Given this list of marker genes FOXRED1, TMEM263, FBXO15, SLC38A2, MINAR1, SLC31A2, ALDH3A2, CFAP206, CD55, SH2B2, PPM1L-DT, PPP1R12A-AS2, FGD3, LINC00265, RALGAPA2, CCDC12, KCNMB4, BORA, NEBL, CHST3, FBXO3-DT, L3MBTL4, THUMPD3-AS1, ADD3, MHENCR (melanoma highly expressed competing endogenous lncRNA for miR-425 and miR-489), MTUS1, CCDC74B, HNRNPA2B1, CEP170, NEK8, SAMD13, RILPL1, GEMIN8, ATXN1L, JADE2, CAV1, CNOT2, DST, MIR4669, ABT1, ENSG00000274248, SERTAD3, KRTDAP (keratinocyte differentiation associated protein), TASOR2, CFAP74, ULK3, AP3S2, ITGB3BP, SMARCAD1, CDKN2B-AS1, ACAA2, TRIM14, HTR6, GSE1, SERTAD3-AS1, STOX1, YARS1, TIMM21, RUNX1, KAT6B (NCBI Gene Id 23522), USP9X, LRRK2-DT, RIPK4, TLE3, LMNB1-DT, TRIP6, IGF2BP2, ZNF143, SDC4, SLCO4A1, MYO3A, FXR1, NTN4, KAT2B, TMEM187, AVPI1, RAB37 (RAB37, member RAS oncogene family), SYCE2, FZD1, LNX2, LAMC1, SPSB4, LHFPL6, JOSD1, BROX, C1QTNF1 (NCBI Gene Id 81852), YKT6, APP, ZNF449, VTI1A, SART3, TRIOBP, PDE4DIPP6, ZNF286B, NEBL-AS1, GGA3 (golgi associated, gamma adaptin ear containing, ARF binding protein 3), MVK, CRTAP, BCL7B, GNAQ, NSG1, NTNG2, FBXO17, DUSP1, DPYSL2, MTF1, ALDH5A1, FLJ38576, DFFB, UBALD1, CBX4, PLS1, ZBTB1, MIR4710, RPL26, RPL9, DENND5A (NCBI Gene Id 23258), RNU1-5P (NCBI Gene Id 107105261), UNC13D, GBA2, GBA1, ADGRE5, CFL1P1, RNU1-6P, SPTBN1, TCEANC, SVIL, QPCT, NCOA4, FLNA, ZNF143-AS1, HNRNPU, FOXN3, CRTC3, VPS72, MGA, LTK, ADAMTS1, FGFR4, PNRC1, C15orf62, MAN2C1, PTPA, MAP1LC3B, METAP1, ZDHHC6, HSPA12A, TSC22D4, MET, ITPK1, BHLHE40, B3GNTL1, ARHGAP10, NEAT1, ADRB1, ARHGEF6, PELP1-DT, TUBA5P, BMPER, ZC2HC1A, ATXN1-AS1, SLC18B1, DICER1-AS1, MRPL14, TUT7 (NCBI Gene Id 79670), ISCA1, TBX18, LIAS, MRPL34, ADCK2, AAAS, STX16, ZNF501, HLA-DMA, ERC1 (NCBI Gene Id 84770), HMG20B, MAK16, LGALS8, TSPAN12, TPTEP2, ZBTB38, ZNF75D, GS1-24F4.2, BBS4, NDE1, CROCC, DGAT2-DT, PRDM10, DDIT4, TARS1, MIR6853, ANKRD36C, SOX18, CEP104, ATP5MFP1, LTV1, MARCKSL1P2, TRIM24, CFAP43, CALCOCO2, SRGAP1, FRMD6, BAG6, PIK3R1, NAGLU, UCHL5, RNPS1, RHPN2, FASTKD3, OSBPL9, NFE2L2, TRMT1, ENSG00000248367, MTF2, MCRIP2, FHIP1A, PPP2CA, SLC25A42, IL5RA, ANXA11 (annexin A11), CCNI2, EEF1D, ZNF703, APC, ZNF593, PRKCH, FRG1HP, COQ10A, TBXA2R, RASGEF1B, KCTD11, TNRC18, PPARG, SGK3, SLC16A6, IFT88, USF2 (NCBI Gene Id 7392), RPS21, FUNDC2 (FUN14 domain containing 2), AP3S1, RCOR3, EPCAM-DT, RRAGD, ABCB10, RANBP9, CNTNAP2, ZBTB7C, MAGI2, GSTK1, LGALS8-AS1, KLHDC8B, UBE3C, PPM1L, GATA3-AS1, GPR6, PSPH, MICAL1, BRF1, NIPAL4-DT, TP73-AS3, HIPK3, CAPN1-AS1, RIOK1, LINC02026, F12, IDUA, NHSL3, CREB3, CC2D2B, NUS1, GCNT2, LINC01126, ABCG4, STK10, LZTS2, TOP3B, WIPI2, DGKQ, CYP2E1, HDGF, PLD1, CDK8, GPR146, VPS26C, MAP3K5, ATF3, RETREG1, ATF7-NPFF, COPB2-DT, CCDC169, NRP1, LINC01703, CHCT1 (NCBI Gene Id 124773), PLEKHA5, LINC02601, ERICH1 (NCBI Gene Id 441310), ATP1A1-AS1, EMILIN2, TRIM47, SGTB, MIR1915, TAGLN2, SLC44A1, VGLL4, AMDHD1, COL24A1, CCNL1, LIN7B, TNK2, USP2-AS1, DTX3, LSM2, ATP1A1, TLCD1, ANP32A, EMB, RALGDS, CUL4A, JAKMIP3-AS1, UBE2G2, ENTPD6, OGG1, CYP1B1, ENSG00000224865, PTK6, SATB1, TGFBR3 (NCBI Gene Id 7049), RGS9, COL25A1, RASEF (RAS and EF-hand domain containing), TCFL5, ADORA2B, CABLES2, SPRED2, GRK6, RANGRF, TMLHE, FBXO31, HSPA5-DT, DBNDD2, AIDA, UTRN, ABCA2, FAM200B, LIFR-AS1, SCRN2, SGSM2, CDCA2, B4GALT3, PTPRG (protein tyrosine phosphatase receptor type G), CYB5D2, CNOT7, DLG3, RNF207-AS1, NUDT19-DT, MIDN (NCBI Gene Id 94034), MGAT4B, SQSTM1, RNF150, KHDC1 (KH domain containing 1), CTIF, CCZ1P1, CA12, PWWP3A, CKB, CMTM8, PTPN6, PPP2R5A, TGFB2-AS1, ATAD1, FOXL1, TPRN, NPAS3, ITPR3, EDIL3-DT, EIF4H, SLC25A37, HSPA5, LTBP3, RAI1, COL25A1-DT, MTX1, MTARC1, ADD3-AS1, HCFC1, ACTN1, ZNF782, BRWD1, SLC1A1, RO60, RAD52, ZNF491, RILP, FRMD5, FBXO3, MAPK9, FGD4, FNTA, WRAP73, SYNJ1 (synaptojanin 1), GNG12-AS1, PDLIM7 (PDZ and LIM domain 7), NDUFAF3, TPT1-AS1, EIF4E1B, SLC16A1, NXNL2, CADM4, ZC3H4, PEX11A, LINC02709, SLC16A1-AS1, ENSG00000280424, ENSG00000273145, ARHGEF12, SNX3, EFNB2, C7orf50, LARP1B, CRY1, LINC00398, STK25, RPIA, CS, YTHDF2, LRMDA, AQP6, MFGE8, ZNF620 (NCBI Gene Id 253639), UQCC5, TBC1D22A, OLIG2, PAM, APC2, PRKAG2-AS1, SCN1B, MTG1, ANKRD18B, HPSE, PAXBP1-AS1, EPC1-AS2, CYP4V2, KRAS, TNFAIP3, CNPY2-AS1, MPHOSPH6, ZNF503, SH3GLB1, RPS27L, HOXB6, RCBTB2, IFNAR1, TMEM105, TMEM123, CFAP52, PNCK (NCBI Gene Id 139728), TGFB1, ROM1, MTMR14, RGS3, DIPK1A, PTGER2, PDE8A, LIMS1, HACD3, MLF2, PANK2, PCID2, EXT2, NAA16, RNVU1-3, SIM2, TM9SF1, RNU6ATAC, HOXB3, TLN1, IBA57-DT, TMEM147, GMEB2, MTUS1-DT, PRCD, APBB2, IFT25, GOPC, BLTP1, SAMD4B (sterile alpha motif domain containing 4B), PUSL1, PPP2R5C, LAMB1, LAGE3, NAIF1, CASTOR3P, EARS2, DDX59 (DEAD-box helicase 59), SPPL3, CASP6, PRKAG2 (protein kinase AMP-activated non-catalytic subunit gamma 2), SMAD2, PEX16, NHSL1-AS1, PARP3, TMEM63B, PGGT1B, WDR93, DARS1-AS1, GATA3, ELL2, SEMA6A, SLC6A8, ZNF639, RARA, MBD6, PDZD7, GPR3, SSBP2, ETS2, ZNF641, RNASEH2B (ribonuclease H2 subunit B), RNF207, TRNT1, MTRR, SPX, ORAI1, TRDMT1, MAP3K8, CUEDC1, CCNQ (NCBI Gene Id 92002), SLC20A1, LRRK2, SH2B3, SLCO5A1-AS1, BRD2, ENSG00000282904, SPATA13, CIP2A, CSAD, CHD3, ETF1, CASC9, RNVU1-15, CACTIN-AS1, ZZEF1, ADCY3, RAMP2-AS1 (RAMP2 antisense RNA 1), G0S2, PDXK, GNA13, SSR4P1, TGFB2, TMEM263-DT, DENND3-AS1 (DENND3 antisense RNA 1), BARX2, ENSG00000277020, ENSG00000266313, BDKRB2, POLR3G, LNPEP, EPHB1, GINS3, SLC20A2, LAMTOR2, F8, CDK18, CTDSP1, TXNL4A, PICALM, PLK3, DNAI3, TP53TG5, SPTBN5, PKN2, RNASET2, PIGC, MTCL1, C21orf58, ASAP2, COL13A1, TOB2, VARS1, ADSL, MARCHF7, NME3 (NCBI Gene Id 96012), KLF13, STX16-NPEPL1, SGK1, BLMH, LBX2, GCLM, IQCD, GGH, RSL24D1, SMIM13, AGAP3, CNR1, SQOR, LDB3 (NCBI Gene Id 1219), ZNF140, PPP1R16A, LINC01586, GLUL, TUBB4A, PHF12, VPS29, ATP6V0E2, VWA5B2, TUBBP5, LINC00881, DAP, KRT8, ZNF607, MISP3, UBFD1, MIR449C, FANK1, IL6ST, FAM201A, JAK2, RBP1, ENTPD1-AS1, SECISBP2, ACAP3, IQGAP2, ACIN1, TRMT9B, NEIL2, GGNBP2, FAM66B, LINC03073, RNU6ATAC34P, PPP1R3B, CHPT1, SH3D21, PNPLA3, SDCCAG8, SLC4A2, R3HCC1, CCDC88B, STMN1, EEF1A1-AS1, WDHD1, TPT1, IER2 (NCBI Gene Id 9592), MNX1, CCZ1, PGF, EPCAM, MILIP, NUDT19, SLC16A2, TTC17, PIPOX, HERC6, BATF3, RAD9B, YWHAE, LINC01424, DPH7, TCEA2, BTG2-DT, FLT3LG, FBN2, HNRNPF, TMEM91, CDC73, CYTH1, P2RX4, OCLN, CBX2, LHX1, DNAJC7, SCARNA17, ACTG1P25, ATOSA, DCLRE1A, SMARCAD1-DT, CCDC38, CCDC110, MCOLN3, CLIC4, NAALAD2, PLEKHA2, LINC03126, MYADM, YWHAQ, GAA, TRIM7, TSPAN5-DT, MIR615, N4BP2L1, STON1, TUBGCP3, NREP, CBX3, MPP2, TGIF1, DDX59-AS1, CTDSP2, ZNF740, LTBP4 (latent transforming growth factor beta binding protein 4), PELP1, CACNA2D4, DYNLL1, IRF5, ATAD3A, ZNF467, TEP1, TTC38, THAP3, SOCS4, TOM1L2, EEF1A1, MBP, ASB1, ZNF10, FBXL5, PHF3, POLR1D, ITPR2, ACVR1B, USP32, ABTB1, MED13L, CNP, XPOT (exportin for tRNA), TMEM123-DT, EWSAT1, PRDM11, LINC00620, CDC37, ITGA7, RTL8B, ANKRD18A, BLOC1S1, TWF2, TIGD3, ENSG00000236846, AKAP10, ZMYM2, STOX2, WDR86, ARID1B, MED12L, TRIB1, RNU4-2, SNIP1, ATP23, TBPL1, NT5DC2, MEF2D, RNF130, ST6GALNAC2 (ST6 N-acetylgalactosaminide alpha-2,6-sialyltransferase 2), KIF21A, ZNF517, MAP3K4, ZNF436-AS1, THEM4, FADS1, TGM2, ATG12, DPYSL4, SLCO4A1-AS2, TUNAR, DALRD3, MYO18A, UAP1, SNX10, TMEM37, SLC16A11, ARL4A (ADP ribosylation factor like GTPase 4A), PLEKHG5, INPP5B-AS1, SLC25A35, OXSR1, DPCD, GINS4, INPPL1, STX8, MYOM2 (NCBI Gene Id 9172), PDE1B, FPGS, SLC3A2, GATA6, FGF11, HSD11B1-AS1 (HSD11B1 antisense RNA 1), CEBPA, DBIL5P, CTSC, HOXB9, TSPAN9, GOLPH3-DT, EPHB6, CBX8, ZNF503-AS2 (ZNF503 antisense RNA 2), KGD4, CUX1, IST1, GPR199P, B9D1, CDK2AP2, VAMP2, RECQL5, SPART, SERPINF1, MPP3, CDC25B, SPR, GLI3, PPP3CB-AS1, STX11, SNCB, NBPF19, SAE1, BBS2, CDC20B, MTA3, HDAC1, KAZN, KDM1A, HMGN2, DLC1, CRIPT, WDR86-AS1, SCD, INAVA, GCC2-AS1, DGAT2, ZNF862, ACBD5, ARHGEF7, TMEM147-AS1, DDX55, CCNE2, GSAP, PDE7A-DT, NACC2, MATK, KMT5C, SPAG4, VARS2, MEF2C, FHIP1A-DT, BMF, DHRS3, TFRC, OSGIN1, SETD5, ITM2B, TARS1-DT, TMEM259, LRFN4, GREP1, LYPD1, SPART-AS1, CCDC33, ATXN1, METTL21A (NCBI Gene Id 151194), DENND4B, NFATC4, TTI2, PITPNM2, ITGB2, KDM4B, PPP1R18 (NCBI Gene Id 170954), CDC42EP3, GFRA3 (NCBI Gene Id 2676), HERPUD1, NIPAL4, EML2, TMEM35B (NCBI Gene Id 100506144), HOXC4, NPPB, MMAB, ZNF770, CASP8, METTL15 (NCBI Gene Id 196074), NPTX1 (NCBI Gene Id 4884), SNHG5, ANTXR2, DNAJC9-AS1, LINC01749, CCT6B, BMP7, KIF18A, CAPN1, SOCS2, AMPD3, FBXO6, HTR3A, LDB1, PRC1, PDZD2, NR4A1, VPS13A, CPE, PCGF1, ACTB, ANK1, SPRY2, DYRK1B, SOS1, LINC02870, DGKH, STPG2, FBXO7, THBS3, CYP4A22-AS1, SIAH2, ICA1-AS1, GAS6, PCBP2, MAGI2-AS3, ROBO2, TSPAN4, HCFC2, FAIM (Fas apoptotic inhibitory molecule), METTL23, MPC1, FUT10, HECTD1, KCTD9 (NCBI Gene Id 54793), CHD4, RALA (NCBI Gene Id 5898), ZDHHC4, RCOR1, MRPL38, KLHL24, ST6GALNAC6, TEDC2-AS1, ELMOD2, TLE6, WNT11, CXADR, LLGL2, RRP9, ATP6V0E2-AS1, GATA6-AS1, HOXA3, DIS3L2, EXTL3, ELFN1-AS1, ARHGEF17, TPM1, ATF7, OGFRL1, PCNT, CD24, HEBP2, SLC25A45, PANK2-AS1 (NCBI Gene Id 107985395), CD99, CDKN2A, CCT6A, DEXI, GCHFR, MFSD12, UBTF, RNF43, IFNLR1, SLC16A3, EPC1-AS1, PSD2-AS1, ING1, NENF, EML3, CCDC169-SOHLH2, MICU2, FABP6-AS1, DLEU1, TC2N, HSPA9 (NCBI Gene Id 91471), FIGNL1, UAP1-DT, JADE3, LINC01145, TRIM33, TCAP, PPM1D, GPSM3, CDC42EP4, PITPNC1, SDC2, ZNF706 (NCBI Gene Id 51123), PDE7A, PDGFA, LMNB1, KLHL32, DENND3, MAX, NBEAL2, TMEM42, PRRT3-AS1, ZNF436, TBCB, MRFAP1P1, MNT, SLCO5A1, CD37, MADD, APP-DT, TSR1, TMEM130, DHRS12, SAMD11, SEPHS1, SIM1, WWP1P1, GALNT10, RNF217, FAM83E, SORBS3, TSPAN5, USP2, ZBTB26, HNRNPA0, NDUFA4, ABCF3, RHOC, CASP7 (NCBI Gene Id 840), RNU6-2, SLC29A2, CAMSAP1, POMP, LINC00938, FAM66C, SEMA4B, HIGD2B, DPF1 (NCBI Gene Id 8193), POGLUT3, KAZALD1, REEP5, PIKFYVE, TM7SF3, HLA-C, CYP27B1, MIR3677HG, GALNT6, GASAL1, GTPBP6, TGFBR3L, CDK4, TBC1D12, MIR5695 (microRNA 5695), SYAP1, CAGE1, CSGALNACT1, NRXN2, MBLAC2, LRRC42 (NCBI Gene Id 115353), ZDHHC14, NRCAM (NCBI Gene Id 4897), HOXA10, DNM2, MACIR, TCP11L2, DZIP3, ANKRD36, DST-AS1, ZNF787, KCNB1 (potassium voltage-gated channel subfamily B member 1), RGP1, MIR4634, GLT8D2, SPTB, WASF2, MARF1, DLST, TLE5, ENSG00000267248, SRPRA, SRSF9, ZBED4, SNHG22 (small nucleolar RNA host gene 22), IDH1, TCF25, SCNM1, TMEM185B, VPS37A (NCBI Gene Id 23687), here is a description of the gene set: Human Gene Set: ZNF423_TARGET_GENES from publication Yevshin I, Sharipov R, Kolmykov S, Kondrakhin Y, Kolpakov F (PMID 30445619) species: Homo sapiens Genes containing one or more binding sites for (ZNF423) in their promoter regions (TSS -1000,+100 bp) as identified by GTRD version 20.06 ChIP-seq harmonization.